Given this list of marker genes ALDH5A1, FH, HSD17B3, PLCD1, ALDH1A1, HPGD, PCCB, ALDH3A1, BBOX1, MPST, MTHFD1, APOC2, GLYAT, AGPAT2, GCSH, SCP2, ECH1, MTHFS, GAMT, GATM, AKR7A3, AMT, CAD, IDH2, LIPC, ASPA, PTS, GOT2, ECHS1, ALDH7A1, PTGIS, LIPA, HPD, ALOX15, ALDH6A1, PLA2G10, ACADVL, ALDH4A1, IDH1, GLUD1 (NCBI Gene Id 2746), QDPR, HADHB, OAT, AKR1C3, HMGCS2, ALOX5, PAH, ACOX2, MGST2, ASS1, CPT2, ACADM, FAH, HMGCS1, PLA2G2A, HAL, GSTZ1, ADH4, HSD17B4, ALDH9A1, ACO2, PLD1, FADS2, GOT1, GAD2, ALDH1L1 (NCBI Gene Id 10840), ASL, SLC27A2, AKR7A2, BAAT, PLA2G7, CYP2J2, PLCG2, GCH1, IGF1, PRDX6, GALE, UGDH, APOC3, CYP4F2, ACOX1, ALOX5AP, here is a description of the gene set: Organic acid metabolism. studied in species Homo sapiens Human Gene Set: MODULE_40